Given this list of marker genes OCRL, INPP4B, MTMR9, ISYNA1, INPP5A, IMPA1, IMPA2, INPP1, MTMR7, INPP5J, MIOX, SYNJ1, INPP4A, INPP5B, here is a description of the gene set: species: Homo sapiens Reactome Pathway: Synthesis of IP2, IP, and Ins in the cytosol Inositol phosphates IP2, IP and the six-carbon cyclic alcohol inositol (Ins) are produced by various phosphatases and the inositol-3-phosphate synthase 1 (ISYNA1). part of: Inositol phosphate metabolism